The following is a description of a gene set: Binding to a complex of RNA and protein. Mouse Gene Set: GOMF_RIBONUCLEOPROTEIN_COMPLEX_BINDING species: Mus musculus, and this is the list of marker genes: Spcs1, Mcts1, Bop1, Rictor, Pitx2, Cpeb4, Shfl, Afg2b (NCBI Gene Id 613261), Ddx3x, Rplp1, Csde1, Abce1, Nvl, Mtrfr, Hspa5, Srpra (signal recognition particle receptor alpha), Ifrd2 (NCBI Gene Id 67007), Derl1, Eif3c, Tma16, Rbm39, Rpl35, Nme1, Rack1, Mtif2, Taco1, Slfn3, Ifih1, Ccdc47, Nopchap1 (NCBI Gene Id 68148), Prmt7, Cpeb1, Pes1, Ezh2, Top2b, Eif1b, Rpsa, Impact, Eif2a, Guf1, Eif2s1, Wdr12, Slfn4, Oxa1l, Prpf31, Eif1a, Rbm3, Fmr1, Sec61bl, Secisbp2, Rplp2-ps1, Rplp1rt, Ybx3, Phf6, Mrrf, Ybx2, Dnajc1, Zfp593, Pqbp1, Derl3, Eif5a2, ENSMUSG00000131459, Naa15, Sbds, D1Pas1, Rnf135, Eif5a (eukaryotic translation initiation factor 5A), Cd2bp2, Gtpbp4, Serbp1, Habp4, Prmt5, Slfn2, Zfp622, Dnajc2, Srp68, Eif3k, Hnrnpc, Gemin5, Cpeb3, Xpo5, Slfn14, Snrnp70, Nmd3, Timm50, Naa16, Snrpd1, Secisbp2l, Larp1, Eefsec, Csnk2b (casein kinase 2, beta polypeptide), Ppih, Sec61a1, Pelo, Gemin4, Smg6, Usp16, Snrpc, Pim1, Hnrnpk, Ythdf3, Rnasel, Ltn1, Rps21, Hnrnpu, Ncln, Tmco1, Derl2, Ppp1ca, Snrpd3, Unk, Eif1, Cbx5, Eri1, Itch, Ndufab1, Snrpb, Stau2, Ythdf1, Pttg1, Srp19, Lonrf2 (LON peptidase N-terminal domain and ring finger 2), Ndufab1-ps, Ptcd3, Prpf6 (NCBI Gene Id 75696), Uhmk1, G3bp1, Srp54a, Letm2, Npm1, Csnk2a1, Dhx33, Mtor, Cpsf6, Ttc39aos1, Eef2, Mdm2, Snrpg, Mrps27, Rpl35rt, Uchl1, Sec61g-ps3, Nemf, Mtres1, Tmem223, Ighmbp2, Tmem147, Mettl17, Letmd1, Mtif3, Letm1 (leucine zipper-EF-hand containing transmembrane protein 1), Dhx29, Malsu1, Gtpbp6, Efl1, Zfp598, Prmt1, Eif4b, Naa10 (NCBI Gene Id 68005), Dapl1 (NCBI Gene Id 76747), Snd1, Sec61b, Ppihl, Nomo1, Eral1, Ddx5, Srp72, Snrpa, Snrpb2, Snrpd2, Snrpn, Strap, Cpeb2, Ago2, Afg2a, Eif4h, Slfn1, Eif4a3l1, Ckap5, Bag6, Xist, Eif4a3, Cinp, Uqcc5, Sec61g-ps2, Nolc1, Ola1, Sec61a2, Ttc5, C1qbp, Pym1, Dap, Map3k20, Fxr1, Dhx9, Snrpe (small nuclear ribonucleoprotein E), Rplp2, Apobec1, Ung, Eif4a3l2, Sec61g, Zc3h12a, Abcf1, Maip1, Eif6, Rpn2